The following is a description of a gene set: part of: Diseases of Cellular Senescence Reactome Pathway: Evasion of Oxidative Stress Induced Senescence Due to p16INK4A Defects studied in species Homo sapiens The CDKN2A gene consists of four exons, exon 1beta, exon 1alpha, exon 2 and exon 3, going from the proximal to the distal gene end. There are two promoters in the CDKN2A gene locus. The promoter located between exons 1beta and 1alpha regulates transcription of the p16INK4A mRNA, which consists of exon 1alpha, exon 2 and exon 3 (only partially translated), and encodes a cyclin-dependent kinase inhibitor p16INK4A (also known as CDKN2A isoform 1, p16, INK4A, CDKN2A, CDK4I or MTS-1). The promoter located upstream of exon 1beta regulates transcription of the p14ARF mRNA, which consists of exon 1beta, exon 2 (partially translated) and exon 3 (untranslated). The p14ARF mRNA is translated in a different reading frame from the p16INK4A mRNA and produces the tumor suppressor ARF (also known as p14ARF or CDKN2A isoform 4), an inhibitor of MDM2 E3 ubiquitin ligase-mediated degradation of TP53 (p53).<br>Wild type p16INK4A is able to form a complex with either CDK4 or CDK6 and prevent formation of catalytically active CDK complexes consisting of CDK4 or CDK6 and D-type cyclins (CCND). Thus, p16INK4A prevents hyperphosphorylation of RB-family proteins, required for initiation of DNA replication in RB1-competent cells. Expression of p16INK4A increases in response to oxidative stress, leading to cellular senescence (programmed cell cycle arrest) under conditions of prolonged oxidative stress. Loss-of-function of p16INK4A frequently occurs in cancer, usually through loss of p16INK4A protein expression due to promoter hypermethylation or CDKN2A gene deletion. Missense, nonsense and frameshift mutations in the CDKN2A locus can also impair p16INK4A function through expression of non-functional substitution mutants or truncated proteins. Germline intronic CDKN2A mutations that create aberrant splicing sites and result in expression of non-functional splicing variants of p16INK4A have been reported in familial melanoma. A CDKN2A gene mutation in the region encoding the 5'UTR of p16INK4A, reported in familial melanoma, creates a novel translation start codon and diminishes translation from the wild type start codon. However, mutations in the non coding regions of the CDKN2A gene are rare.<br>p16INK4A defects enable cancerous cells to evade cell cycle arrest and senescence under prolonged oxidative stress. A cell cycle-independent role of p16INK4A in regulation of intracellular oxidative stress has been reported.<br>Genomic deletions in the CDKN2A locus affect p14ARF, unless they are limited to exon 1alpha. The p14ARF promoter can also be hypermethylated in cancer, leading to loss of p14ARF expression. Some missense mutations occurring in exon 2 of the CDKN2A gene affect the p14ARF protein sequence. However, p14ARF mutants usually appear to be less functionally compromised than their p16INK4A counterparts. Most functional tests on p14ARF mutants examine the effect of mutations on MDM2 binding and TP53-mediated transcription of CDKN1A (p21), as well as sub-nuclear localization of p14ARF. Still, there are poorly explored functions of p14ARF that may be significantly affected in mutant p14ARF proteins detected in cancer., and this is the list of marker genes: CDK4, CDK6, CDKN2A